The following is a description of a gene set: An abnormality of the upper respiratory tract. Human Gene Set: HP_ABNORMALITY_OF_THE_UPPER_RESPIRATORY_TRACT studied in species Homo sapiens Abnormality of the upper respiratory tract, and this is the list of marker genes: HNRNPA1 (NCBI Gene Id 780920), C4B, HIRA, DNAAF3 (NCBI Gene Id 56162), TERC (telomerase RNA component), PARN, SOD1, SATB2, LBR, HDAC4, STK36 (NCBI Gene Id 27148), LRP12, SERPING1, ODAD2, CYBB, ZBTB7A, MYSM1, NOTCH2NLC, HAAO, TBX1 (NCBI Gene Id 7413), STAT3 (signal transducer and activator of transcription 3), ARSB, RSPH4A, SCNN1G, KAT6B, FMR1, CR2, LTBP3, POLD1, PON1, RAF1, P4HA2, FERMT1, KIF22, CHD7, LTBP4, DCTN4, PTEN, CFAP221, SLC29A3, COG4, CFTR, UBE3B, KDM5C, HMOX1, ROBO1, SCARF2, RAG2, CIITA, PRKCD, AIRE, PRMT7, LRRC56, HLA-DPA1, CHCHD10, IKBKB, RSPO1, HYOU1, CDKN2A, RNF168, SH2D1A, IDH1, ADARB1, COL5A1, NEK10, UFC1, FBXW7, DOCK8, NFKBIA, ZBTB24, MEG3, HOXD13, DCTN1 (dynactin subunit 1), PNP, APC, WRN, DCLRE1C, KRT5, OFD1 (OFD1 centriole and centriolar satellite protein), SLC11A1, ARVCF, DNAAF11, IVNS1ABP, SH3KBP1, LIG4, ADAMTSL2, RREB1, GCLC, FLNB, UNC119 (NCBI Gene Id 9094), CORO1A, MS4A1, LMNA, RTEL1, CFAP45, LEP, SLC9A3, SIAH1, SRP19, NAGLU, IRF1, SMAD4, PON3, STX1A, IFIH1, TP63, HNRNPR, FOXE1, BRWD1, DNAAF6, ALG12, UBQLN2, EPHB4, TGFB1, PSMB8, ARSL, IGHG2, SOX4, KATNIP, CHEK2, LONP1, COL5A2, NEFH, SOX9, PDE11A (phosphodiesterase 11A), MSH2, RFX7, PLP1, USP9X, GNPTAB, GRIP1, CCDC39, PRRX1, SPEF2, MAGT1, NME8, HLA-DPB1, MDM4, TYMS, ODAD3, RSPO2, AGA, AFF4, GRIN2A, TINF2, PUF60, DNAAF2, PRTN3, TREM2, CTSK, MT-CYB, H3-3A, DDRGK1, CREBBP, HLA-B, NCF1, SOX11 (NCBI Gene Id 6664), PCNT, ATRX, MKS1, NRCAM, TERT (telomerase reverse transcriptase), AICDA, PMS1, MAN2B1, DEAF1, RAG1, COL12A1, TONSL, KRAS, DNAH5, DNAAF4, RSPH9, TSPYL1, CXCR4, MGAT2, CFI, FOXN1, WAS, PHIP, CCNF, STX3, NOTCH2, IGHM, MLH1, TRIM37, CARMIL2, IL17RA, TNFRSF13C, HSPG2, DNAJB13, CACNA1C, RALGAPA1, DYNC2H1, DNAAF1, UNC13A, CCDC40, CHMP2B, ACP5, DNAH1, AHDC1, BLNK, GAS2L2, EPCAM, MID1, RAI1, KCNN4, PIK3CA, CFAP74, MEIS2, SLC39A7, FANCB, SCNN1B, ANO3, GBA1, PLVAP, PON2, ZAP70, DRC1, STXBP2, ALX3, TARDBP, POLR3A, IRF2BP2, RFX5, NEK1, GLE1, PORCN, GABRG2, KCNJ2, SIX2, UNG, PPM1D, SCNN1A, FREM2, SYT1, DAO, DNAJC21, ALMS1, MST1R, WIPF1, LAMB3, ARHGEF1, ATP6V1E1, RPL10, IL6ST, GUSB, ASXL3, WNT3, TAP1, GFI1, RILPL1, CILK1, ARID1B, GLI3, EDN1, FGFR3, FCGR3A, RSPRY1, GJA1, DKC1, DNAI1 (dynein axonemal intermediate chain 1), MGP, PIK3R1, RSPH1, IGKC, RUNX2, SF3B4, HFE, ZMYND10, RSPH3, ZNF341, GLB1, FGF10, KANSL1, ORC6, BLM, NLRP12, FUS, SMAD2, GALNS, KCNMA1, TNFRSF13B, DNAL1, ICOS, HYLS1, NFIX, STK4, DNAAF5, RNU4-2, MYMX, GMNN, ACBD6, FUCA1, CTC1, LAMC2, IL7R, PTPN22, NCF2, TCF3, CAT (catalase), IL21R, CYBA, LRBA, WDR35, CLXN, ZNF699, CEACAM6, SEMA3E, TNFRSF1A, FOXP1 (NCBI Gene Id 87246), HPS6, ARID1A, SALL4, DYNC2LI1, NOP10, RNH1, PRKAR1A, CEACAM3, SRPX2, LEPR, MYMK, KRT14, TMCO1, IKBKG (inhibitor of nuclear factor kappa B kinase regulatory subunit gamma), ARID2, POLR1A, CFAP410, IQSEC2, NFKB1 (NCBI Gene Id 4790), IFT80, FLII (NCBI Gene Id 2314), NPM1, SMARCA4, PMS2 (PMS1 homolog 2, mismatch repair system component), CLCA4, GNS, SLC26A9, EDNRA, MCIDAS, DHCR7, PRPH, ANG, EXTL3, PIK3CD, SEC61A1, TP53, CFAP52, GSTM3, IGSF3, SMARCD1, NHP2, INTU, ATXN2, XIAP, SMCHD1, STK11, PKDCC, ADNP, MIF, NME5, HYDIN, GLT8D1, PFN1 (NCBI Gene Id 5216), PGM3, CD79B, PSAP, BTK, FGFR2, STAT1, CCDC103, ADA, ATM, FOXJ1, UFD1, CFAP300 (cilia and flagella associated protein 300), SEC24C, CD4, AMER1, FCGR2A, F12, PPARGC1A, DYNC2I1, SPAG1, DNAI2, LRRC8A, IGLL1, MBTPS2, CD81, TAF1, POLE, SLC6A14, HS3ST6, TBK1, G6PC3, DPF2, ZIC3, ERBB4, SETBP1, SLC26A2, VAPB, ALX1, NFKB2, LCK, SNIP1, LAMA3, JMJD1C (jumonji domain containing 1C), DNAH11, CSPP1, NF1, MSH6, NIN, TBX3, DTYMK, EFL1, RAC2, SGSH, ASAH1, COMT, KIF7, IDS, TTC12, MAP3K7, DNAH7, BRF1, MATR3, SBDS, MDM2, KAT6A, GIPC1, VPS13B, FRAS1, TAP2, CTLA4, TCOF1, SMARCB1, GP1BB, CLPB, POR, WRAP53, DYNC2I2, EP300, CD19, ICOSLG, RPGR, DLK1, SERPINA1, CCDC65, TGFBR2, PRPS1, HLA-DRB1, SLC4A10, RTL1, SMARCE1, DYM (NCBI Gene Id 54808), PSMB4, XPNPEP2, IRF8, SFRP4, TCTN3, DNAH9, TBC1D24, CAPN15, CENPE, ODAD4, OPTN, PRNP, C2CD3, FLNA (filamin A), RFXAP, VCP, SMARCC2, ODAD1, PLG, SPTBN1, LRP4, TNFRSF9, NLRP1, IL6R, TNFSF12, SPI1, DDX3X, SHH, TBX4, COL11A1, CYBC1, NBN, GALC, FIG4, ADA2, BTD, HGSNAT, ELANE, RFXANK, POLD3, HCK, CASR, PTH1R, IL2RG, TCIRG1, SCN4A, JAK3, ANXA11, CCNO, CFAP298, CD79A, SASH3, EIF4A3, NCF4, H3-3B (NCBI Gene Id 3021), SQSTM1, UQCRH, TAF15, MDFIC, MPDU1 (NCBI Gene Id 9526), DNMT3B, USB1, SLC37A4, RELB